The following is a description of a gene set: from publication Tabula Muris Consortium (PMID 32669714) studied in species Mus musculus Mouse Gene Set: TABULA_MURIS_SENIS_KIDNEY_KIDNEY_LOOP_OF_HENLE_ASCENDING_LIMB_EPITHELIAL_CELL_AGEING, and this is the list of marker genes: Pigr, Spink1, Napsa, Apoe, Wfdc2, Kap